The following is a description of a gene set: Genes up-regulated in I/11 erythroblast cells upon expression of an activated form of FOXO3. studied in species Mus musculus The cooperation of stem cell factor (SCF) and erythropoietin (Epo) is required to induce renewal divisions in erythroid progenitors, whereas differentiation to mature erythrocytes requires the presence of Epo only. Epo and SCF activate common signaling pathways such as the activation of protein kinase B (PKB) and the subsequent phosphorylation and inactivation of Foxo3a. In contrast, only Epo activates Stat5. Both Foxo3a and Stat5 promote erythroid differentiation. To understand the interplay of SCF and Epo in maintaining the balance between renewal and differentiation during erythroid development, we investigated differential Foxo3a target regulation by Epo and SCF. Expression profiling revealed that a subset of Foxo3a targets was not inhibited but was activated by Epo. One of these genes was Cited2. Transcriptional control of Epo/Foxo3a-induced Cited2 was studied and compared with that of the Epo-repressed Foxo3a target Btg1. We show that in response to Epo, the allegedly growth-inhibitory factor Foxo3a associates with the allegedly growth-stimulatory factor Stat5 in the nucleus, which is required for Epo-induced Cited2 expression. In contrast, Btg1 expression is controlled by the cooperation of Foxo3a with cyclic AMP- and Jun kinase-dependent Creb family members. Thus, Foxo3a not only is an effector of PKB but also integrates distinct signals to regulate gene expression in erythropoiesis. from publication Bakker WJ, van Dijk TB, Parren-van Amelsvoort M, Kolbus A, Yamamoto K, Steinlein P, Verhaak RG, Mak TW, Beug H, Löwenberg B, von Lindern M (PMID 17353275) Mouse Gene Set: BAKKER_FOXO3_TARGETS_UP, and this is the list of marker genes: Asah1, Nf2, C630043F03Rik, Ccng2, Rgs2, 4833420G17Rik, Pnpla6, Tcp11l2, Vopp1, Nqo2, Cdkn1b, Ctse, Ulk1, C330018D20Rik, Trp53inp1, Pik3ip1, Osbpl9, Dstn, Nkiras2, Btg1, Csf2rb2, Hipk1, Ccpg1, Cr2, Pgm2l1, Sirpa, Xpo7, Klf6, Hscb, Ampd2, Cpeb4, Zfp60, Kit, P2ry14, Dcp1a, Pink1, Chic1, Dennd5b, Tmx1, Pggt1b, Sft2d2, Gucd1, Gria3, Slc12a6, Sesn1, Vcl, Dcn, Cpt1a, Dnajc12, Rbl2, Cited2 (Cbp/p300-interacting transactivator, with Glu/Asp-rich carboxy-terminal domain, 2), Gnai2, Atp7a, Zup1, Arg1, Uncx